The following is a description of a gene set: Human Gene Set: GOBP_GASTRO_INTESTINAL_SYSTEM_SMOOTH_MUSCLE_CONTRACTION A process in which force is generated within smooth muscle tissue, resulting in a change in muscle geometry. This process occurs in the gastro-intestinal system. Force generation involves a chemo-mechanical energy conversion step that is carried out by the actin/myosin complex activity, which generates force through ATP hydrolysis. The gastro-intestinal system generally refers to the digestive structures stretching from the mouth to anus, but does not include the accessory glandular organs (liver, pancreas and biliary tract). studied in species Homo sapiens, and this is the list of marker genes: TACR2, KIT, PTGER3, NMU, GHSR, SULF1, GHRL, SPX, HTR2B, SCN11A, SULF2, HTR1D